The following is a description of a gene set: Large iliac wing Increased size of the ilium ala. species: Homo sapiens Human Gene Set: HP_LARGE_ILIAC_WING, and this is the list of marker genes: GUSB, RNU4ATAC, ATP7A (NCBI Gene Id 613259), B3GALT6, SMAD4, AMER1 (NCBI Gene Id 160176)